Given this list of marker genes HDAC6, DIAPH3, RAC1, NEMP1, RAC2, TRIM58, here is a description of the gene set: A developmental process, independent of morphogenetic (shape) change, that is required for an enucleate erythrocyte to attain its fully functional state. An enucleate erythrocyte is an erythrocyte without a nucleus. Human Gene Set: GOBP_ENUCLEATE_ERYTHROCYTE_MATURATION species: Homo sapiens